Given this list of marker genes APOB, LIPC (NCBI Gene Id 3990), EPHX2, GPIHBP1, PLTP, PCSK9, APOA2, APOA4 (apolipoprotein A4), LDLRAP1, LPL, LCAT, APOA1, LDLR, CETP (cholesteryl ester transfer protein), USF1, GHR (growth hormone receptor), here is a description of the gene set: studied in species Homo sapiens Human Gene Set: WP_FAMILIAL_HYPERLIPIDEMIA_TYPE_2 Familial hyperlipidemia type 2